The following is a description of a gene set: studied in species Homo sapiens from publication Chen Y, Wang X (PMID 31504780) Human Gene Set: MIR617 Genes predicted to be targets of miRBase v22 microRNA hsa-miR-617 in miRDB v6.0 with MirTarget v4 prediction scores > 80 (high confidence targets)., and this is the list of marker genes: SRGAP2C, ZNF146, GINS3, STXBP1, DGKH, CDKN2A, SEC22A, PRPS2, MIA3, ST8SIA3, CEP350, ELF2, KLF7, PSMD12, JPH1, ITCH, SAE1, PAX9, HSPA2, AIG1, LRRC19, RFXAP, SRGAP2B (NCBI Gene Id 730266), PDK2, PDGFRL, AKT3, CDK19, SLC14A1, SMAD3, SLC2A4RG, CTBP1, NKIRAS1, MAN2A2, EPHA10, ZFX (NCBI Gene Id 7543), EPHA7, E2F3, PCMTD1, MLX, CHD2, GLT8D1, SURF4, MYO5A, LEPROT, MYOCD, CSRNP3, EVI2A, BLTP3B, MAP2K4, STPG2, PLD6, CACUL1, PPA1, SCARA5, ZFAND3, NQO1, CMC1, TENT4B (terminal nucleotidyltransferase 4B), TTC14, PWWP2A, DDX27, RAD54L2, SORBS1